Given this list of marker genes GOLGB1, KCNQ1OT1, MAP3K1, STMN4, FAM181B, VCAN, DOCK10, MAP2, SPRY4, MXD4, SESN3, DCX, BTG2, KLHL24, SOX6, MMP16, SOX4, CADM2, DLL3, OLIG1, TXNIP, DSEL, ABAT, HIP1, KDM5B, SOX5, TANC2, BAZ2B, OLIG2, BTG1, RAB3IP, PNRC1, TFDP2, GLCCI1 (NCBI Gene Id 113263), CHD7, KLF12, GRIA2, RFTN2, FGFBP3, ZMYM2, UBE2H, REV3L, TRIO, SOX11, RFX4, ARHGEF7, LDLRAD3, ZNF91, MTSS1, PEAK1, here is a description of the gene set: species: Homo sapiens Genes upregulated in subsets of cells of a given type within various tumors from publication Gavish A, Tyler M, Greenwald AC, Hoefflin R, Simkin D, Tschernichovsky R, Galili Darnell N, Somech E, Barbolin C, Antman T, Kovarsky D, Barrett T, Gonzalez Castro LN, Halder D, Chanoch-Myers R, Laffy J, Mints M, Wider A, Tal R, Spitzer A, Hara T, Raitses-Gurevich M, Stossel C, Golan T, Tirosh A, Suvà ML, Puram SV, Tirosh I (PMID 37258682) Human Gene Set: GAVISH_3CA_MALIGNANT_METAPROGRAM_29_NPC_OPC In this study, an extensive analysis was conducted to define meta-programs (MPs) capturing intra-tumor heterogeneity across a spectrum of tumor types. The approach utilized non-negative matrix factorization (NMF) to analyze each cell type separately within individual tumor samples. This involved the analysis of malignant cells, macrophages, fibroblasts, endothelial cells, epithelial cells, T-cells, and B-cells. NMF was executed with varying parameter values (K=4, 5, 6, 7, 8, 9), thereby generating 39 programs for each cell type per sample. Each NMF program was summarized by the top genes based on NMF coefficients.\nRobust MPs were then delineated for each cell type using a set of stringent criteria, including recurrence within the same tumor, similarity to programs in other tumors, and non-redundancy within a tumor. Subsequently, these robust NMF programs were clustered (per cell type) based on Jaccard similarity, leading to the identification of MPs associated with each cell type.\nTo enhance the quality of the MPs, a refinement steps were undertaken, involving the removal of MPs suspected of reflecting low-quality data (with an overrepresentation of ribosomal proteins or mitochondrial-encoded genes), single-study inclusion, or similarity to miss-annotated cell types.